Given this list of marker genes ATOH7, SLIT2, FEZF2, MYCBP2, YTHDF1, KIF21A, POU4F2, ROBO3, TUBB2B, PTPRO, NOVA2, TBR1, here is a description of the gene set: Human Gene Set: GOBP_REGULATION_OF_AXON_GUIDANCE Any process that modulates the frequency, rate or extent of axon guidance. studied in species Homo sapiens